The following is a description of a gene set: Targeted therapy in breast cancer species: Homo sapiens Human Gene Set: WP_TARGETED_THERAPY_IN_BREAST_CANCER, and this is the list of marker genes: PIK3C2B, ERBB2, RAF1, MAPK1, ERBB4, PIK3R3, KRAS, AKT1, MAPK3, AKT3, PIK3CA, PIK3C2G, PIK3R6, EGFR, PIK3R5, PIK3C2A (NCBI Gene Id 5286), PIK3R2, ERBB3, PIK3CD, HRAS, AKT2, PIK3R1, NRAS (NCBI Gene Id 4893), PIK3CB, PIK3CG, PIK3R4